The following is a description of a gene set: Human Gene Set: HP_METOPIC_SYNOSTOSIS Metopic synostosis species: Homo sapiens Premature fusion of the metopic suture., and this is the list of marker genes: SIX2, DDB1, PIGA, FREM1, WDR35 (WD repeat domain 35), CDK8, FBXO11, PIGT, FGFR1, HNRNPK, IL11RA, NFIA, PTCH1 (NCBI Gene Id 8015), PCDHGC4, SON, DIAPH1, MSX2, UBAP2L, GLI3, PPFIBP1, GPC3, TMEM216, GPC4, POLR1A, ERF, OTUD5, HERC1, ASXL3 (NCBI Gene Id 80816)